The following is a description of a gene set: studied in species Mus musculus Reactome Pathway: Keratan sulfate degradation This event has been computationally inferred from an event that has been demonstrated in another species.<p>The inference is based on the homology mapping from PANTHER. Briefly, reactions for which all involved PhysicalEntities (in input, output and catalyst) have a mapped orthologue/paralogue (for complexes at least 75% of components must have a mapping) are inferred to the other species. part of: Keratan sulfate/keratin metabolism electronically inferred by orthology from the curated human pathway, and this is the list of marker genes: Galns (galactosamine (N-acetyl)-6-sulfatase), Hexb, Glb1l2, Lum, Omd, Kera, Glb1l, Hexa, Acan, Glb1l3